The following is a description of a gene set: studied in species Mus musculus Genes predicted to be targets of miRBase v22 microRNA mmu_miR_7217_3p in miRDB v6.0 with MirTarget v4 prediction scores > 80 (high confidence targets). Mouse Gene Set: MIR_7217_3P from publication Chen Y, Wang X (PMID 31504780), and this is the list of marker genes: Hdac9, Kcnq2, Sorbs2, Rnf217, Dusp16, Nbea, Map3k8, Cyp3a41a, B3glct, Set, Phox2b, Atp10b, 0610040J01Rik, Adk (adenosine kinase), Arhgap17, Phtf1, Cyp3a11, Pcdhb10 (protocadherin beta 10), Moxd1, Rer1, Esyt2, A1cf, Zfp141, Pramel30, Tpd52l2, Psme4, Olfml1, Uqcrq, Nfat5 (NCBI Gene Id 54446), Eif5a2, Zfyve1, Glis1, Rcsd1, Zfp827, Trmt9b, Btg2, Bag1, Esp15, Syt11, Ror1, Tepsin, Asb4, Irak1, Eif4g2, Cers3, Myt1, Map2k6, Numb, Zfp386, Cdc37l1, Uros, Samd10, Sh3bgrl, Slc39a9, Lrrc31, Foxs1, Cdc42bpa (CDC42 binding protein kinase alpha), Traf6, Svs6, Lep, Slc25a14, Sbspon, Esp16, Guf1, Myo6, Sec14l1, Fbrsl1, Sema3g, Klhl29, Rpgr, Fsip1, Mmachc, Cubn, Gstm2, Zbtb9, Cyp3a41b, Ank2 (ankyrin 2, brain), Mat2a, Adarb1, Hif3a, Wnt10b, Krtap6-3, Pramel14, Cxxc4, Cyld, Seh1l (NCBI Gene Id 72124), Camta1, Retreg3, Prickle2 (prickle planar cell polarity protein 2), Foxo6, Purg, Cep170b, Tmem230